The following is a description of a gene set: species: Homo sapiens from publication Chen Y, Wang X (PMID 31504780) Genes predicted to be targets of miRBase v22 microRNA hsa-miR-135a-5p in miRDB v6.0 with MirTarget v4 prediction scores > 80 (high confidence targets). Human Gene Set: MIR135A_5P, and this is the list of marker genes: PDCL, STRBP, BMPER, ATP2B4, NADK2, C1orf198, BMAL1, ACSL5, EYA1, ACVR1B, VPS37C (NCBI Gene Id 55048), VLDLR, LONRF1, RNF43, KCNQ5, PTPRT, HECTD2, DEPTOR, NDRG4, ZCCHC24, ELOVL6, MICAL2, NTNG1, NEFM, PRKD3, HPS5, FBXO28, CACNA1D, G3BP1, FOXN3, CPD, NAMPT, MB21D2, TGM2, RASAL2, SLITRK4, CPLX2, GULP1, MBTD1, DCUN1D4, UBE3C, MYPOP, NET1, ANXA7, CAP2, ROBO1, UIMC1, B3GLCT, PGGT1B, SSR2, PPP6R3, LMTK2, CSNK1G2, ESRRA, PSIP1, LZTS1, SHISA6, BCAP29, HMGXB3, BSN, ANKRD55, TMEM168, ENPP3, SLC26A4, ABCE1, PTPRD, AGPS, SLC30A4, KIAA1143, DNAJC9, SERTAD2, USP42, ZNF131, UGT2B4, STAU2, APC, HERC3, BZW2, KLF4, SLC24A2, CSPP1, ATG14 (autophagy related 14), SRSF3, KALRN, EFNB2 (NCBI Gene Id 1948), DIP2C, COL4A3, PELI2, RALGAPB, WWC2, ACTR3B, NR3C2, ELK3, MRAS, ARHGAP11A, MED13, C2CD2, IGF2BP2, MAPKBP1, ENTPD4, HMBOX1, SIRT1, GRIA3, CACNA1E, MAPK10, MEF2C, PDS5B, SAMD9L, THRB, CAAP1, BTAF1, ZNF670, WAPL, SYT2, ST6GAL2, DDX3Y, SIAH1, TMEM97, GCNT2, MTSS1, ZFP1, PKIG, FAM120B, SHISA7, GARIN1B, ZBTB44, PSD3, BAHCC1, AVPR1A, CCDC170, SYT3 (synaptotagmin 3), CDYL2, GRIA4, KDM7A, ATP1B1, CADM3, PIM2, MAPRE2, SLC9A9, ZNF385B, STK35, INTS2, TRPC1, CLVS2, BCL11A, RIC1, GRID2, ARHGAP19, C6orf120, MTMR12, SV2B, ZNF302, PHLDB2, NUFIP2, FOXN2, ZNF652, HOXA10, C18orf54, PRUNE2, MXRA5 (matrix remodeling associated 5), GAS7, PRLR, RBAK, RAPGEF6, KIAA1549, TSTD2, ILDR2, SEMA3A, ADAR, ROCK1 (NCBI Gene Id 6093), AEBP2, SPATA2, TRAPPC8, DDX60L, ANK3, ASB13, PPARGC1B, PPM1E, ORC5, ZNF143, VCAN, KCNB1, PREPL (NCBI Gene Id 9581), ZNF681, GCLM, PIK3R2, NCLN, TWSG1 (twisted gastrulation BMP signaling modulator 1), SDCBP, DAG1, SMAD5, TBC1D4, NUDT5, ZBTB46, SLC16A6, SEC14L1, SETBP1, SPRED1, OSBPL8, SMIM13, SAMD8, CD47, KCTD10, MRPS12, NCOA2, VAMP2, TNPO1, TCF19, KCNJ6, GNG7, KIF3B, TCF7L2, BCAT1, LATS2, PCYT1B, CTTNBP2, ZSWIM4, SLC25A5, PDE1A, LMCD1, ILRUN, KCNN3, DEPDC1, SNX16, CREBZF, ATP8A1, RPS6KB1, ATXN7L1, MEAK7, ELK1, IL31RA, FRMPD4, DDX3X, MRPL16, ZNF518A, PIGH, SCN2A, RNF138, SETD7, TMPO, COL5A1, KCNS3, ADO, TOPORS, MOB1B, ZCCHC14, SNTB2, JAK2, RALBP1, BRWD1, UGT2B10, TAF4, CEP85L, LYPLA1, WASHC4, BACH1, CCSAP, MFHAS1, KCND1, CPLX1, EDNRA, ZBTB34, PGAM1, KRAS, GK5, ARHGEF4, ZRANB1, CHD1, YWHAG, JAKMIP2, GSK3B, ANGPT2, STK38L, CRAMP1, MAN1A1, TSEN54, EBF1, USP15, CNTNAP1, SLC10A7, CNIH4, MTMR2, FCHO2, GRIK3, SV2C, UTRN, KCNAB3, RUNX2, FOXO1, CHMP4B, ERBB4, HNRNPR, RGL1, NBEA, ROCK2, WNT3, HIF1AN, ENTPD7, ARHGAP6, SSR1, ZRANB2, PEX7, UNC13A